Given this list of marker genes CD164, HELZ2, PLS3, CASTOR1, ITPRIP, QPCT, C1orf54, IVNS1ABP, CXCL2, AAMDC, TAMALIN, SELENOP, SH3BP4, TACC1, MYRIP, CPD, DPEP1, APLN (NCBI Gene Id 8862), EGR2, FOXL2NB, S1PR1, JAM2, PROSER2, VWA2, ATP8B1, POLD4, IFI27, MT1E, DOCK9, LMCD1, ZYX (NCBI Gene Id 7791), TRAM2, SLCO2A1, SLC16A3, DEDD2 (death effector domain containing 2), PLAUR, ENTPD1, PLAAT3, MSN, CRTAP, CRACDL, NPC2, SOX7, FUT1, NOS2, TNFRSF14, SHANK3, DIPK2B, KLF13, MFRP, PARP9, NQO1, SLC22A23, MMRN2, PECAM1, PGF, TBX1, MALT1, GAS6, CERS2, ZFP36L1, SLCO2B1, FLVCR2, CLIC2, ELOVL1, MYLK2, SAT1, TUBB6, FCHO2, VWF, TCF4, TLR4, SLC26A2, MYORG, GNA14, SNHG8, SOCS3, EHD4, TNS1, C2CD2L, MDN1, LCP2, ANXA1, CLEC3B (NCBI Gene Id 7123), HEY2, CSRP1, NR4A1, SLC38A5, CTDSP1, CD19, SLC39A8, MCL1, RPS6KA3, HTRA1, ZBTB38 (zinc finger and BTB domain containing 38), ANGPT2, FSTL1, LIMS1, TSC22D3, ICOSLG, YPEL2, APRT, SNX3, ARAP2, LRRC36, CXCL12, WIPF1, SDC3, MPP1, DNASE1L3, PER1, IL4R, PLVAP, FOXQ1, CALCRL, ERVMER34-1, FLT4, NIBAN1, USP53, CDH11, FKBP1A, PGAP6, B2M, ARC, WDR1, ITPRIPL2, JUN, RAPGEF3, NEDD9, CEACAM21, INSR, TMEM19, JUP (junction plakoglobin), CDC42EP2, JAK1, XAF1, PDXK, DYSF, EPAS1, UACA, APOLD1, CAST (NCBI Gene Id 831), PREX1, MEF2A, IGFBP7, CD4, SVIL, STAT6, TCF15, EMP1, GLRX, WWTR1, SMTN, ADM, RHOC, IFI16, MYL12A, CSRP2, SULT1C4, SLC7A11, DOK4, WDFY1, SLC38A2, PTPRG, FAM124B, CAV2, ARHGAP18 (Rho GTPase activating protein 18), FOXN3, TMSB4X, ITPKB, LYL1, FRMD8, REEP3, RASGRP2 (NCBI Gene Id 10235), ECM1, SERPINB8, XIRP2, TAX1BP3 (NCBI Gene Id 30851), SMAGP, CCNY, FZD6, TCIM, ELL2, ICAM2, SMARCA2, LGALS9, SESTD1, ARHGEF15, MEGF6, PCDH12, CAVIN1, VIM, DCBLD1 (discoidin, CUB and LCCL domain containing 1), IGFBP3, TMEM45B, ETS1, HSPG2 (NCBI Gene Id 7796), CCN2, TMEM35B, SLC16A14, ABCG1, PLA2G4C, CD82, ADAMTSL2, RGL1, N4BP3, ANKRD37, EGFL7, TMC6, ETS2, SEMA3G, ACTN1, HDAC7, RAPGEF4, GPCPD1, IRF1, CGNL1, SLC16A4, CDK7 (cyclin dependent kinase 7), PIK3IP1, KLHL6, JPH1, NECTIN2, TEK, RPS6KA2, PZP, KANK4, LAYN, PMAIP1, FSCN1, MAP4K3, ITGA5, TCN2, SNRK, TFRC, GADD45A, ADGRF5, HSPA2, SYNGR2, MICOS10-NBL1, DENND3, HRCT1, MAP3K11, ASB9 (NCBI Gene Id 79067), MKNK2 (NCBI Gene Id 2872), MAST4, MYCBPAP, CD27, PFKL, TBX3, TNS2, MECOM, AHNAK, GIMAP6, SCARF1, C1orf115, AP1S2, CYBA, MYO5C, RCSD1, PELO, USHBP1, DDIT3 (DNA damage inducible transcript 3), PLSCR1, TLN1, RHBDF2, MT2A, HID1-AS1, ANXA4, MTUS1, EGR3, DGKE, ST3GAL1, CASP1, FN1 (NCBI Gene Id 2335), BCAP29, FLNB, SPRY4, ISG15, GJA1, LTA, VCL, NPDC1, ABCG2, DSP, PTGS2, ICAM1, TIMP1, ADAMTSL4-AS1, CLEC2B, PIK3R6, IL32, SLC52A3, CDKN1A, STOM, GZMA, SLC3A2, RASGRP3, PLEKHA1, SLC1A4, MCAM, SH3TC1, CCNL1, RGCC, SHROOM1, CCDC186, PLLP, NOX4, THBD, CA2, PICALM, NMI, C2CD4B, JUNB, AFF1, DUSP1, ADORA2A-AS1, CD81, NID2, CLIC4, CRIM1, ZFAND2A, SOS1, PODXL, KLHL29, NOD1, KLF4 (NCBI Gene Id 9314), PPFIBP1, PCED1B, SLC2A1, LRRC8C, EMP2, TLE1 (NCBI Gene Id 7088), HBB, SOX17, SERPINE1, BNIP2, TAGLN2, TES, SCARB1, FOXF2, PNP, TMC7, EFNB2, ANGPTL4, SPINK8, STAT3, KITLG, VAMP3, LSR, HSD17B14, PIK3CB, NHERF2, CDA, PRCP, ST6GALNAC1, MYO1B, ULBP2, SLC5A6, DUSP6, BCL6B, CPNE5, ACVR1, MGST2, LAMA4, GIMAP1, ITGB1, COX7A1, GRPEL2, HBA2, PARP14, SNHG12, TNFRSF1B, PHLDA1, PDE8A, ADGRL4, SNAP23, CD55, GPD1L, PRICKLE2, TPM4, CAVIN3, NR4A3, EDN3, EVA1B, NRP1, ABLIM1, SEL1L3, SLC7A5, SLC16A2, MGAT1, CHST7, GADD45B, ISM1, FOXF1, STING1, LONRF3, FCGRT, FXYD5, KLF2, LPP, IER2, CHST15 (carbohydrate sulfotransferase 15), FBLN2, POMP, MIR155HG, FOXC1, DAP, CTHRC1, MEF2D, CSGALNACT1, PDK4, KLF1, HPGD, FKBP5, RIGI, CLIC5, ICAM4, CCN1, RALB, SPX, NRP2, SGK1, CCDC68 (NCBI Gene Id 80323), LAMB2, RHOB, GATA2, ABLIM3, MIR22HG, TXNIP, ANXA3, ZIC3, GUK1, RNF144B (ring finger protein 144B), HLX, NPR1, TWIST1, SP6, FAM43A, OSMR, PINK1, GPR146, PGGHG, GNG11 (G protein subunit gamma 11), TJP1, ADORA2A, SMCO4, HERPUD1, CYB5A, TSPAN14, ZC3HAV1, USP54, MT1F, ADAM1A (ADAM metallopeptidase domain 1A (pseudogene)), PON2, AFAP1L2, ADGRA2, LDLR, MAP4K2, TMEM255B, INPP5D, ACSS1, SLC7A1, LHX6, RNF19A, ARHGAP29, PXN, CSRNP1, PKIG, BSG, TM4SF18, LEF1, MFSD2A (NCBI Gene Id 84879), IFITM2, STARD8, SERPINH1 (serpin family H member 1), MYO6, LTBR, ITPR3, IKBKE, SH2B3, TAF1C, PPM1H, CD93, B4GALT1, SH3PXD2A, SDCBP, LAPTM4A, DLL4, TM4SF1, SLC4A1, FLT1, ABCA1, SHROOM4, BOK, TM6SF1, GDPD5, RFTN2, ABCB1, MAP3K1, SPOCK2, NOS3, TMEM229B, AFAP1L1, SIK1, SMAD6, MIR211, SLC16A5, ADGRL2, RBMS2, EMCN, NPIPB5, ID1, ELN, MMP28, ZNF366, VEGFC, KLF6, TIE1, KIAA1671, IGFBP2, TCIRG1 (T cell immune regulator 1, ATPase H+ transporting V0 subunit a3), LSMEM1, NEIL1, RCAN1, CAVIN2, TOMM40, EEA1, ADAM15, TNFRSF1A, HIC1, CASP3, SH2D3C (SH2 domain containing 3C), OSTF1, LEPR, TGM2, PLEKHG2, CKMT2, NR1D1, VASH1, PALMD, PITPNA, ASAH1, SLC35F2 (NCBI Gene Id 79593), ID3, SOD2, FAR2, TSPAN9, MFNG, FGR, IL6ST, CCDC85B, DOCK6, MMD, RAPH1, CCT8L1P, STARD4, PRSS12, APOL4, BMP4, FRMD4B, SLCO1A2, DHRS3, DENND2C, KANK3, IFI44L, KDR, CCDC141, ZIC5, LIFR, LRP8, BCL3, ANXA2R, CFLAR, ABCB4, SQOR, MYO1C, PROCR, LDB2, SMG1P3, IGFBP4, PIEZO1, MYL12B, TTN, MYC, CARD8, CPNE2, SYPL1, ZBTB2, TMEM123, PTPRB, ADM5, LIPA, ST6GAL1, HOPX, SMAD7, STAB1, SOX18, GGT5, CXCL1, PABPC4L, F11R (NCBI Gene Id 50848), ALPL, TP53I11, AMOTL1, CDKN2B, TGFB1 (NCBI Gene Id 7040), AKAP12, MCF2L, EGR1, FAM89A, ICA1, LMO2, CLDN5, TMEM37, YES1, SERINC5, PEAK1, KCNJ2, COBLL1, ECE1, PTPRM, SLC7A8, BCAM, FCGR2A (NCBI Gene Id 90764), KL, ABHD17A (NCBI Gene Id 81926), PRX, PLCB3, SRGN, ERC2-IT1 (NCBI Gene Id 711), SLK, RAPGEF5, HYAL2, TRIM38, PAQR5, IRF2, VWA1, ADAMTS1, RBP1, MYZAP, ADCY4, ROBO4, PRKD3, TPD52L1, ERF, ITM2A, LRRC55, GNG5, KANK2, TOR4A, DUSP5, SLC2A3, PLK2, PAM, BTNL9, YBX3, REST, PFN1, LATS2, FOXL2, PDE4B, CCM2L (NCBI Gene Id 140706), RAMP2, VAMP5, WASF2, SERTAD1, SLC9A1, TTC29, LAMC1, TIAM1, RNF135, PLOD1, PDE7B, ESAM, STARD13, RBPMS, FRMD6, VIP, FOSB, PALD1, KLHL5, AJAP1, ARAP3, SELE, VSIG2, EPHA2, DTX3L, MBNL2, ERG, MBTPS1, IFI44, SUCLG2, ZFP36L2 (NCBI Gene Id 96706), TTYH2, STRA6, TBXA2R, LUZP1, EDN1, ARPC1B, RGS3, GMFG, PXDC1, SHE, TMEM88, TGFBR2, CETP, PKP4, GRN, LYSMD2, HSPB1, FES, TBC1D4, APCDD1, PNRC1, KRT5, LDLRAP1, FAM78A, NPAS2 (neuronal PAS domain protein 2), SLC46A3, HHEX, ACTN4, ANXA11, ECSCR, FOLH1B, FGD5, DAB2, CDH5, GPR155, TFEB, MIR17HG, NPIPB3, CAV1, IQGAP1, ITGA6, LIMS2, GAB1, LXN, PRXL2A, SHC1, RRAS, CASP4, MYCT1, EOGT, LHFPL2, RHOA, ACVRL1, ESM1, IFITM3, ITGA1, ANXA5, SEC14L1, RBMS1, GJC2, GBP4, EPHB4, GIMAP7, NAMPT, SQSTM1, IFI6, ACSL5, STX3, MYH9, F2RL1, EFCAB14, WFS1, SLC16A1, RHOJ, ARHGEF12, GRAP, HAPLN1, GBP6, CD34, CEMIP2, ITSN2, HSPA12B, GDF15, A2M, CXCL8, FOS, GIPC3, PLXND1, TSPAN5, TMBIM1, CASP12, HAPLN3, RASIP1, EFNA1, DNASE1L1, ENG, APLNR, RNASE1 (NCBI Gene Id 6035), NLRC3, ITPRID2, GJA4, CREM, RELL1, MAFF, MT1X, LAMB1, FHL3 (NCBI Gene Id 2275), MMP25 (matrix metallopeptidase 25), ELF1, GNAI2, TRAM1, CREB5, JAG1, IFI35, FZD4, UNC5B, HBG2, NOSTRIN, SERPINB6 (NCBI Gene Id 5269), HBEGF, HES1, SLC31A1, PDGFB, FLI1, SPSB1, HBA1, ENTREP2, MEF2C (NCBI Gene Id 4208), PLIN2, ARHGEF1, ZFP36, SPTBN1, HBG1, FMNL3, RARG, IQGAP2, PARP12 (poly(ADP-ribose) polymerase family member 12), SLC39A1, CHST3, KLF3, GPR4 (NCBI Gene Id 2828), GIMAP4, ESYT2, MAGT1, HEG1, THSD1, CA5A, ZIC2, LPAR6, PCAT19, WIPI1, SRARP, CSF3, GABRE, SCML1, CYYR1, MSRB3, FABP4, CD59, UTRN, CNN2, PRKCH, PTBP1, CPT1A, CLEC1A, NR3C1, ACE, ACOT9, CLEC14A, PRDM1, JAG2, GALNT18, GIMAP5, JCAD, MATN3, SLC38A3, RAB13, RASSF3, AXIN2, SMAD1, SPTSSA, EPHX4, NKD1, STXBP2, TNFAIP1, RPS28, ISLR, PLEKHG1, DEGS2, PLCG2, TMOD3, MAOA, PPIC, KRT14, here is a description of the gene set: Cell types are named using anatomical and functional mnemonics prefixed by 'm' or'h' to indicate mouse and human respectively: OMTN, oculomotor and trochlear nucleus; Sert, serotonergic; NbM, medial neuroblast; NbDA, neuroblast dopaminergic; DA0-2, dopaminergic neurons; RN, red nucleus; Gaba1-2, GABAergic neurons; mNbL1-2, lateral neuroblasts; NbML1-5, mediolateral neuroblasts; NProg, neuronal progenitor; Prog, progenitor medial floorplate (FPM), lateral floorplate (FPL), midline (M), basal plate (BP); Rgl1-3, radial glia-like cells; Mgl, microglia; Endo, endothelial cells; Peric, pericytes; Epend, ependymal; OPC, oligodendrocyte precursor cells. studied in species Homo sapiens from publication La Manno G, Gyllborg D, Codeluppi S, Nishimura K, Salto C, Zeisel A, Borm LE, Stott SRW, Toledo EM, Villaescusa JC, Lönnerberg P, Ryge J, Barker RA, Arenas E, Linnarsson S (PMID 27716510) Human Gene Set: MANNO_MIDBRAIN_NEUROTYPES_HENDO